Given this list of marker genes Dcstamp, Cd44, Adam9, Ocstamp, Tyrobp, Trem2, Stat1, Cd81, here is a description of the gene set: species: Mus musculus The binding and fusion of a macrophage to one or more other cells to form a multinucleated cell. Mouse Gene Set: GOBP_MACROPHAGE_FUSION